Given this list of marker genes CD63, INO80D, MMP24 (matrix metallopeptidase 24), PIM2, PSMD2, DTX4, ZNF264, SYNJ2, GAB2, KDM5C, EFNA5, FAM72A, ITPR1, SAP30L, PLEKHG4B, NOP16, MPP2, PKD1L2, HOXA10, TMEM47, FYN, PHACTR1, URB1, ERG, SENP1, FHIP2A, FAM72D, TFAP4, TMEM178B, KIF13B, NECTIN1, SCAMP1, CBX6, OGT, CCN2, BEAN1 (NCBI Gene Id 146227), TSPAN1, TRAF3, XG, CHMP1A (charged multivesicular body protein 1A), FBXL19, KCNJ6, DTWD1 (DTW domain containing 1), PTGER2, HSPB7, WFS1, TNNI1, NIBAN2, SYNGAP1, CTDSP1, FAM72C, NACC1, OSR2, TSPYL2, FAM72B, CAMK2B, CAVIN4, HBB, ELK1, EMP1, CPEB1, POU2F2, ATP2A3, AP2A1, YIPF1, GIGYF1, HEATR1, DSPP, NCOA2, TMEM167B, TFE3 (NCBI Gene Id 8244), MSI2, IVD, ATXN1L, TGFBR3, ABI1, PIK3C2B, CGNL1, LRTM2, TBC1D16, NFAT5, PRRT2, STUM, ZNF618, MOV10, NUFIP2 (NCBI Gene Id 57532), MLLT6, HIF3A (NCBI Gene Id 93988), EEF1AKMT3, MEIS2, KLHL21, HACD1, H3-3B, ALDH3B2 (aldehyde dehydrogenase 3 family member B2), CCN5, RIMS4, KPNA1, NEK10, RNFT2, ADCY5, RNF112, AKAP13, here is a description of the gene set: Genes predicted to be targets of miRBase v22 microRNA hsa-miR-361-3p in miRDB v6.0 with MirTarget v4 prediction scores > 80 (high confidence targets). from publication Chen Y, Wang X (PMID 31504780) species: Homo sapiens Human Gene Set: MIR361_3P